Given this list of marker genes PLAAT1, PLEK (NCBI Gene Id 5341), CD48, CD247, CD8A, OGN, CD52, F2RL2, ADRA2A, SLC40A1, SNTG2, ITGBL1, FAXC, HOXA10, RAI2, SPP1, ADM, TRBV5-4, LCP1, MIR99AHG, VGLL1, FRZB (frizzled related protein), GZMA, RUNX3, GIMAP5, CXCL14, here is a description of the gene set: Genes in the stroma-derived prognostic predictor of breast cancer disease outcome. from publication Finak G, Bertos N, Pepin F, Sadekova S, Souleimanova M, Zhao H, Chen H, Omeroglu G, Meterissian S, Omeroglu A, Hallett M, Park M (PMID 18438415) studied in species Homo sapiens Although it is increasingly evident that cancer is influenced by signals emanating from tumor stroma, little is known regarding how changes in stromal gene expression affect epithelial tumor progression. We used laser capture microdissection to compare gene expression profiles of tumor stroma from 53 primary breast tumors and derived signatures strongly associated with clinical outcome. We present a new stroma-derived prognostic predictor (SDPP) that stratifies disease outcome independently of standard clinical prognostic factors and published expression-based predictors. The SDPP predicts outcome in several published whole tumor-derived expression data sets, identifies poor-outcome individuals from multiple clinical subtypes, including lymph node-negative tumors, and shows increased accuracy with respect to previously published predictors, especially for HER2-positive tumors. Prognostic power increases substantially when the predictor is combined with existing outcome predictors. Genes represented in the SDPP reveal the strong prognostic capacity of differential immune responses as well as angiogenic and hypoxic responses, highlighting the importance of stromal biology in tumor progression. Human Gene Set: FINAK_BREAST_CANCER_SDPP_SIGNATURE